Given this list of marker genes Calcr, Calcrl, Ramp3, Ramp2, Ramp1, here is a description of the gene set: species: Mus musculus A protein complex which is capable of calcitonin family receptor activity. Calcitonin family receptors may form dimers, trimers or tetramers; adrenomedullin and amylin receptors have only been observed as dimers so far. Mouse Gene Set: GOCC_CALCITONIN_FAMILY_RECEPTOR_COMPLEX